The following is a description of a gene set: species: Homo sapiens Genes down-regulated in polarizing CD4 Th17 cells: untreated versus digoxin. from publication Huh JR, Leung MW, Huang P, Ryan DA, Krout MR, Malapaka RR, Chow J, Manel N, Ciofani M, Kim SV, Cuesta A, Santori FR, Lafaille JJ, Xu HE, Gin DY, Rastinejad F, Littman DR (PMID 21441909) Human Gene Set: GSE27241_CTRL_VS_DIGOXIN_TREATED_CD4_TCELL_IN_TH17_POLARIZING_CONDITIONS_DN CD4+ T helper lymphocytes that express interleukin-17 (Th17 cells) have critical roles in mouse models of autoimmunity, and there is mounting evidence that they also influence inflammatory processes in humans. Genome-wide association studies in humans have linked genes involved in Th17 cell differentiation and function with susceptibility to Crohn’s disease, rheumatoid arthritis, and psoriasis1-3. Thus, the pathway towards differentiation of Th17 cells and, perhaps, of related innate lymphoid cells with similar effector functions4, 5, is an attractive target for therapeutic applications. Mouse and human Th17 cells are distinguished by expression of the retinoic acid receptor-related orphan nuclear receptor RORγt, which is required for induction of IL-17 transcription and for the manifestation of Th17-dependent autoimmune disease in mice6. By performing a chemical screen with an insect cell-based reporter system, we identified the cardiac glycoside digoxin as a specific inhibitor of RORγt transcriptional activity. Digoxin inhibited murine Th17 cell differentiation without affecting differentiation of other T cell lineages and was effective in delaying the onset and reducing the severity of autoimmune disease in mice. At high concentrations, digoxin is toxic for human cells, but non-toxic synthetic derivatives, 20,22-dihydrodigoxin-21,23-diol (Dig(dhd)) and digoxin-21-salicylidene (Dig(sal)), specifically inhibited induction of IL-17 in human CD4+ T cells. Using these small molecule compounds, we demonstrated that RORγt is imporant for the maintenance of IL-17 expression in mouse and human effector T cells. These data suggest that derivatives of digoxin can be used as chemical probes for development of RORγt-targeted therapeutic agents that attenuate inflammatory lymphocyte function and autoimmune disease., and this is the list of marker genes: TCERG1L, TPM4 (NCBI Gene Id 7171), RPL10P17, SRM, GNL3, MDFIC, JAK3, ENTPD1, HHEX, ZDHHC9, APOL6, LGMN, CUTA, ANK3, DZIP3, SULF2, VIM, ECHDC2, HYAL1, BLNK, ANXA2R (annexin A2 receptor), INPP5D, MYO1F, ELP2, LIPA, NOP53, P2RY14, RRP12, GIMAP4, TUBA4A (NCBI Gene Id 93373), CLEC11A, ARMCX1, HLA-B, ZYX, ID2, ZXDB, CACHD1, FAM219B, TNFSF11, SMS, TKTL1, FZD3, PPM1F, IPO4, TARP, FCN1, NOLC1, KRTAP4-3, FOXO1, NOC3L, SH2B3, RAB13, TPD52, BAG3, SH2D3A, NOP16, STK4, MTUS1, RHOBTB3, TNFSF13B, MAP4K4, EIF3L, KCNQ1, REXO2, EEF1G, IFRD2, FOXK1, ST3GAL1, HCAR3, NFATC2, ANTXR2, DGKZ, PEA15, PHB1, WDR6, POGK, PEX3, DACT1, PLEKHA1, LDB2, FYN, URGCP, SPATS2L, HES1, TBC1D8, XAF1, RALGDS, TMBIM6, TNF, GPX4, SCML4, PDE4B, PCED1B, PABPC1, IRF9, IRF7, CD40LG, GUSBP11, TCL1A, FCGBP, ZFP36L1, SMYD5, DDX60, GIMAP7, ANKRD55, AHNAK, CPNE2, SRPX, PRR5, ENTR1, BLVRA, TTC3, CALCOCO2, FRMD4A, KICS2, SOAT1, AIG1, EDAR, PIK3IP1, LRRC37A16P, LARS1, PTRH2, TRAP1, STAT5A, RPL14, QPCT, BATF3, ADGRA3, BTLA, OAS1, AHR, IL27RA, CTSL, HSH2D, JAKMIP1, GPR18, SLC39A6 (NCBI Gene Id 25800, solute carrier family 39 member 6), VAMP8, NUP43, TNRC18, PFKM, NFKBIA, TMEM200A, LRRN3, RIMS3, MAST3, GBP1, TMEM204, SMAD7, GALNT6, ENSG00000289161, PER1, ELMOD3, CAPN2, LFNG (LFNG O-fucosylpeptide 3-beta-N-acetylglucosaminyltransferase), CDRT4, MFSD10, ADI1, MYO7B, FBXO6, RNF170, ZC3H8, RAB30, FXN, MBOAT1, TRMT1, SRI, EIF4G1, BTN3A2, ZC3HAV1L, MAOB, LRRC8C, KARS1, FAM43A, GPA33, OXNAD1 (oxidoreductase NAD binding domain containing 1), GIMAP2, RGS18, CD6, JADE2, ADA2, ATP1A1, SRPRB, DENR, FXYD5, ST6GAL1, TGFBI, LINC01120, IFIT3, SCO2, APOBEC3G, USP18, C15orf48, ANPEP, MCL1, RSAD2, HCK